The following is a description of a gene set: from publication Aizarani N, Saviano A, Sagar, Mailly L, Durand S, Herman JS, Pessaux P, Baumert TF, Grün D (PMID 31292543) Human Gene Set: AIZARANI_LIVER_C5_NK_NKT_CELLS_3 species: Homo sapiens, and this is the list of marker genes: PIK3R1, IL2RG, KLRF1, CD2, IL2RB, CNOT6L, SLFN5, PLEK, SYK, WIPF1, ITGB2, GFOD1, GNLY, RUNX3, PRDM1, PLAAT4, ETS1, STK17A, NKG7, IPCEF1, GZMA, ADGRE5, GZMK, EOMES, SLC38A1, CD160, PITPNC1, CD3E, CBLB, TRDC, PTPN22, SLAMF7, SRGN, TRBC2, CYTIP, PDE7A, TYROBP, TOX, SLAMF6, TSC22D3, PTPRCAP, PARP8, ITGAL, BIN2 (NCBI Gene Id 51722), MYBL1 (NCBI Gene Id 649850, MYB proto-oncogene like 1), FYN (FYN proto-oncogene, Src family tyrosine kinase), LCP1, SLA, SH2D1A, TAGAP, IFITM1, RPS27, ZFP36L2, CD247, SYTL3, AOAH, TXK, PIP4K2A, SASH3, IKZF1, CORO1A, NCAM1 (neural cell adhesion molecule 1), CMC1, PRKACB, DENND2D, PIK3IP1 (NCBI Gene Id 113791), FCER1G, ARHGDIB, PTPN4, NR4A2, CD96, CD53, BTN3A1, KLRC1, RAC2, KLRB1, CD7, GZMB, CELF2, S1PR5 (sphingosine-1-phosphate receptor 5), PFN1, IKZF3, KLRK1, CCL5, HCST, XCL2, RNF125, AREG, XCL1, IFNG (interferon gamma), HLA-F, DUSP2, RASSF5, NCR1, PYHIN1, FCMR, KLRD1, BTG1, TIGIT, RASA2, SPON2, CCL4, CST7, SH2D1B, CXCR6, PRF1, PTPRC, MAPK1, PTGER4, FYB1, PVRIG, MCTP2, PRKCH, ALOX5AP, CXCR4, CD69, CCND2, AKNA, ARHGAP9, ARPC5L, CTSW, TRGC1, CCL3L3, CCL4L2, GNG2, GNPTAB